The following is a description of a gene set: studied in species Homo sapiens part of: Semaphorin interactions Activated Rac1 bound to plexin-A might modulate actin dynamics through the sequential phosphorylation and activation of PAK, LIMK1 and cofilin. Reactome Pathway: Sema3A PAK dependent Axon repulsion, and this is the list of marker genes: PLXNA3, FYN, FES, RAC1, PLXNA2, PAK2, LIMK1, HSP90AB1, SEMA3A, PLXNA4 (plexin A4), CFL1, HSP90AA1, PAK3, NRP1, PLXNA1, PAK1